Given this list of marker genes Htt, Camk4, Stat3, Wnt3a, Nsmf, Rela, Jak2, Nrg1, Anks1b, Kpna1, Cabp1, Crtc1, Abi1, Rnf10, Prr7, Kpna2, here is a description of the gene set: studied in species Mus musculus Mouse Gene Set: GOBP_POSTSYNAPSE_TO_NUCLEUS_SIGNALING_PATHWAY The series of molecular signals that conveys information from the postsynapse to the nucleus via cytoskeletal transport of a protein from a postsynapse to the component to the nucleus where it affects biochemical processes that occur in the nucleus (e.g DNA transcription, mRNA splicing, or DNA/histone modifications).